Given this list of marker genes Chuk, Bmp7, Gata6, Amelx, Ccdc154, Eda, Ctnnb1, Slc24a4, Odam, Traf6, Nfic (nuclear factor I/C), Ctnna1, Shh (NCBI Gene Id 20423), Fgf10, Foxc1, Smo, Fam20c, Amtn, Smpd3, Dlx1, Relt, Acvr2a (NCBI Gene Id 11480), Wnt10a, Enam, Klk4, Rogdi, Hand2, Wdr72, Ascl5, Tbx1, Atf2, Dicer1, Pdgfra, Hdac1, Jag2 (NCBI Gene Id 268606), Lef1, Lrp4, Sostdc1, Csf3r, Hdac2, Stim1, Csf1, Itgb6 (NCBI Gene Id 93831), Serpine1, Hand1, Edaradd, Ift88, Bmp2, Cnnm4, Nectin1, Mir875, Edar, Dll1, Cftr, Dspp, Lrp6, Mmp20, Fgf4, Tnfrsf11b, Bcl11b, Tgfb1, Trp63, Foxi3, Apcdd1, Foxo1, Itga6, Gli2, Bmpr1a, Msx1, Klk5, Tcf7l2, Prkcb, Dlx3, Tcirg1, Runx2, Msx2, Tnc (tenascin C), Bsg, Bcl2l11, Wnt7b, Slc4a2, Nkx2-3, Bmp4, Pitx2, Gli3, Dmrt3, Perp, Bax, Ambn, Nf2, Wnt6, Ppara, Dmp1, Rspo2, Ngfr, Acvr2b, Lama5, Odaph, Lhx8, Fst, Fgf8, Adm, Fam20a, Ankrd11, Dlx2, here is a description of the gene set: studied in species Mus musculus The process whose specific outcome is the progression of a dentin-containing tooth over time, from its formation to the mature structure. A dentin-containing tooth is a hard, bony organ borne on the jaw or other bone of a vertebrate, and is composed mainly of dentin, a dense calcified substance, covered by a layer of enamel. Mouse Gene Set: GOBP_ODONTOGENESIS_OF_DENTIN_CONTAINING_TOOTH